The following is a description of a gene set: Human Gene Set: WP_NETWORK_MAP_OF_SARSCOV2_SIGNALING Network map of SARS-CoV-2 signaling studied in species Homo sapiens, and this is the list of marker genes: IKBKG, TBKBP1, IL21, IFITM3, IFI44L, CXCL6, FGA, TRAF3, ATG13, MLST8, ADAM9, CXCL9, SDF2, COQ8B, IL5, CCL21, APOC1, IFNB1, CCL1, VPS11, NFKB2, GSN, CEBPB (NCBI Gene Id 90277), PIAS1, EIF4A2, CXCL2, NTRK1, CLCC1, CCL26, IRF3, VPS33A (NCBI Gene Id 65082), NKRF, JAK2, CASP5, RRAS, VPS41, GABARAPL2, EGR1, TPO, SAA2, GTSE1, IFITM1, SERPINE1, CTSL (NCBI Gene Id 1514), AKT1, SRP19, IL4, AHR, TBK1, HP, FGB, FN1, DDIT4, APOD, NEK9, TNFSF10, FYN, RAP1GDS1, NPTX1, UPF1, JAK1, JUNB, PTPN6, IL22, APOM, APOH, TRPM2, GGH, TGFBR2, HLA-DRA, RPS6, FGG, IL18, PMPCB, TRO, ACTG1, LARP1, C1S, CD14, PARP2, CAMK4, SERPINA5, SIGMAR1, IRAK1, CTSB, ATE1, IGLL1, STAT1, AKT1S1, BTN3A1, C8A, HBD, IL33, HLA-DRB5, ACE2, CXCL1, SMAD5, DUSP1, CTSZ, CRP, TRIM59, SMAD1, CD247, ULK1, MX1, CD8B, EIF4E, HRG, OS9, HSPA8, COL7A1, ITIH4, CXCL5, TRAF2, ATP13A3, MMP25, IL18RAP, BID, CARD11, MIB1, CCL3, ALB, APOA1, CCL2, APOL1, LBP, MYD88, ITGA3, FOS, IL17A, CD2, IRF9, IFIH1, IFI6, IL1B, G3BP2, CXCR2, CFI, CXCL10, MAPK8, SRP72 (NCBI Gene Id 6731), MOV10, PRG3, VPS16, CASP8, SELP, PRKCQ, IL9, CXCL13, GP1BA, ERLEC1, IL1R2, CD163, SAA1, CCL20, ZAP70, STEAP3, TOMM70, IL16 (interleukin 16), CCNB1, CCL8, CDK1, CXCR1, LGALS3BP, SRP54, EIF4EBP1, C1QBP, ITCH, IL13, IFIT1, ITIH3, CPN1, VPS18, CD226, CCL15, CFP, NLRP1, VPS36, RPTOR, MAP1LC3B, TP53I3, CASP9, FAM83A, TF, IL6, BST2, DEPTOR, CASP3, OAS2, NFATC3, CXCL16, CD3E, IL12A, CCL11, PITRM1, CCL4, CFB, WDR74, CXCL12, NLRP3, G3BP1, FGF2, UGGT2, HIF1A, CCL22, RTN4, TRAF6, GTF2F2, CTSD, C1R, IL7, APOA2 (apolipoprotein A2), IGFBP3, CCL5, RAC1, CCR5, CCNB2, LRG1, PF4, ATP6AP1, CD8A, CCR6, ACTB, CXCL8, TNF, SERPINA10 (serpin family A member 10), INTS4, MTOR, MARK2, HLA-DRB1 (NCBI Gene Id 730415), MDN1, CFH, IFI27, AGT, CXCL3, RIGI, RHEB, BIRC5, IL1A, JUN, TLE3, CCL27, RRM2, MAVS, PTGS2, CD3G, SKAP1, IL10, TLE1, CD4, LCK, HBB, IFNG, FAM98A